The following is a description of a gene set: An axon part that is located adjacent to the nodes of Ranvier and surrounded by lateral loop portions of myelin sheath. studied in species Mus musculus Mouse Gene Set: GOCC_PARANODE_REGION_OF_AXON, and this is the list of marker genes: Kif13b, Sptan1, Kcna1, Mag (NCBI Gene Id 17136), Sirt2, Cldn5, Sptbn4, Ncmap, Nfasc, Dlg1, Ank3, Ermn, Gjc2, Epb41l3, Scn2a, Cntnap1